The following is a description of a gene set: species: Mus musculus from publication Yevshin I, Sharipov R, Kolmykov S, Kondrakhin Y, Kolpakov F (PMID 30445619) Mouse Gene Set: ZFP808_TARGET_GENES, and this is the list of marker genes: Gm15901, Hspa8, Tyw1, Lag3, Gm6872, Ogt, Ube2i, Slc43a1, Gm19815, Gm4847, Sema4d, Atg16l1, Dnajb2, Abo, Fhip2b, Stk38l, Ptrh2, Alg11, Hspa4, Gm24400, Ppp2r5c, Rps27a-ps3, Irf8, Hsd11b1, Bloodlinc, Arrdc3, Spcs1, Lst1, Mrm2, Gm2800 (predicted gene 2800), Lyg1, Dclre1a, Limk2, Setd7, Agpat2, Pdia3, 2210417A02Rik, Dnai2, Cxxc1, C030013C21Rik, Slc1a2, Lrp2 (low density lipoprotein receptor-related protein 2), Gm8398, Fau-ps2, Znfx1, Hhip, Jakmip1, Ninj2, Hsp90ab1, Mrpl30, Ints5, Gm15032, Msrb3, Slc1a3, Fastkd5, Nabp2, Lztr1, Foxp1, Fam83c (NCBI Gene Id 71405), Kcnt2, Mpi, Pou2f2, Gtdc1, Sinhcaf, Galnt17, Adamts19, Atp5f1a, Hyls1 (HYLS1, centriolar and ciliogenesis associated), Tram1, Sass6, Dhtkd1, Ino80d, Bola2, Maf, Prkag1, Tor1aip1, Ash2l, Fcgr3, Phf24, Cbfb, B4galt6 (NCBI Gene Id 56386), Babam1, Xpr1, Gm26207 (predicted gene, 26207), Gm7027, Pisd-ps1, 4933406P04Rik, Naprt, Ddx19a, St13, Gripap1, Plcd4, Gm12980, P2rx7, Sez6, Snhg14, Nell1, Top3a, Hspa9, 2610206C17Rik, Vcp, Gm5764, Tra2a, Bcl2l1, Ercc2, Il4, Cd180, 2810407A14Rik, Slc6a4, Slc22a19, Mirlet7f-2, Zfat, B4galt7, Dgcr8, Pdcd6ip, Ech1, Diaph1, Gm12440, Bcas1, Gm10069, Tspyl2, Poc1a, Prss40, Rsrp1, Spmip3, Fkbp4, Pomgnt1, Timm13, 4933434E20Rik, Cep41, Wfs1, H2-M5, Atrnl1, Ino80dos, Prss54, Phox2b, Zfp7, Phlpp2, 0610031O16Rik, Tldc2 (TBC/LysM associated domain containing 2), Eef1a1, Eaf2, Cldn22, Gm23054, Matk, Mbtps2, Gm12936, Psmd2, Niban2, Nipbl, Prrt1b, Ywhag, 4932412D23Rik, Tfdp1, Mir124a-1hg, 9430015G10Rik, Gm15927, Crem, Gm26885, Gm12125, Myh13, Cp, Eva1c, Rabl6, Vwa3b, Med1, Mir1306, Mgst2, Tdrd9, Vmn1r193, Nr6a1os, Gm12892, Usp14, Eri3, 1700023H06Rik, Fbxo21, Snora57, Gm12740, Rpl35a-ps6, Psma3, Mir7057, Mir98, Snx1, Utp25, Gm7094, Ubqln4, Zfp207, Best4-ps, Gm14095, Tsc22d4, Rpl38, Ctsh, Glis3, Dgkz, Gm29707, Rtl1, Nuak2, Pou6f1, Zbtb8a, Gm22973, Gm28874, Arhgap4, Mkks, Gm10532, Iho1, Treml4 (triggering receptor expressed on myeloid cells-like 4), Ptp4a1, Zpbp2, Gm24461, Mcm2, Morc4, Rhot1, Gm24888, Clec2l, Myo18a, Itpr2, Doc2g, Fbrsl1, Gm13207, Sp1, Gm22935, Clec2d, Unc13b, Dpep3, Tigd4, Fam193b, Sos1, Cldn34c1, Lrrc23, Meg3, Mir7664, Psph, Anp32e, Ly6g, Atcay, Spns1, Gemin2 (gem nuclear organelle associated protein 2), Rbm41, Zfp36l1, Gm11149, Ttf2, Mdk, Gnl3, Tulp3, Plcb2, Gm25369, Tgif1, Vwf, Xpnpep3, Fam98c, Mir99ahg, Frrs1, Bmt2, Gm12091, Dhx9, Hsph1, Misp, Abca16, Slc25a2, Xpnpep2, Slx1b (SLX1 structure-specific endonuclease subunit homolog B (S. cerevisiae)), Gamt, Zfp809, Mzf1 (NCBI Gene Id 53862), Tatdn2, Spry4, Gm9887, Ckap2, H3c11, Foxc1, 1700120B22Rik, Abcc3, Sbno1, Rsf1, Dync1h1, Gm3830, AY074887, Gm13842, Mgst3, Slc2a3, Zfp143, Arhgap26, Slx4ip, Nmnat3, Evl, C630004M23Rik, P2rx3, Ppp4r4, Dsc1, Trpm1, Pla2g6, Arhgap27os1, Tpm3, Stap2, Klhl18, Trim36, Zfp865, Gm27219, Bin2, Cdc42ep1, Tcf4, Adarb1, Fam193a, Zfp747l1, Chchd2-ps, Aste1, Lgmn, Rnf6, Vac14, Mir7668, Fuca1, Dnaaf9 (NCBI Gene Id 98941), Atp7a, Gm9496, Znrf4, Gm23382 (predicted gene, 23382), Trp53cor1, Hoxa7, 5031434O11Rik, Ipo13, Fam216a, Cep85, Ly96, Vgll4, 1700001K19Rik, Mpnd, Tor1aip2, Rora, Kdm5a, Syt3, Traj58, Tpk1, Rad54l, Gm14210, Gnl3l, Tango2, Ccndbp1, Igfbp4, 4931406C07Rik, Recql5, Itih3, Hexd, Tshz1, Gtf2i, Uba1, Nme4, Npdc1, Nrde2, Stk32b, Zfp82, Capza1, Inpp5b, Cyb5r1, 4930447F24Rik, Kif20a, Hmgb1, Amz1, Taf1d, Agap1, Plekha6, Ptges3, Atrip, Slc7a3, Agtrap, Myo15a, Suv39h1, Oplah, Mir7035, Phf20, Gm43772, Tanc1, Nadk2, Capn10, Mir5136, 1700020L13Rik, Gm16096, Mtif3 (mitochondrial translational initiation factor 3), Babam2, Strada, Wdfy3, Rnf170, Ankrd40, Bmal1, Esr1, Agap3, Gm26211, Atp6v0a1, Gtf2a1, Defb47, Hint1, Tamm41, 1110028F18Rik, Pask, Catsper2, Ubxn1, Gm11665, Zc3hc1 (NCBI Gene Id 68773), Scin (scinderin), Oas2, Rwdd4a, Fignl1, Surf6, 4933440N22Rik, Setd1a (SET domain containing 1A), Adat1, Gsdma2, Chrna9, Pls3 (NCBI Gene Id 236867), Tle2, Arl2bp, Mfsd14b, Gak, Elk4, Sptan1, Klf1, Ammecr1, 2410002F23Rik, 4930512H18Rik, Pglyrp3, Lars1, Arpp21, Mrpl14, 2010109A12Rik, Mir3618, Zfr (zinc finger RNA binding protein), Zfp27, Gm4535, Faddos, 2310011J03Rik, Adig, Tmco2, Gm28836, Gm14111, Shmt1, Gm12654, Gm13010, Kat2b, Gm9955, Or10ad1, Gm42799, Trip12, Rexo2, Rprl3, Mir8090, Nrbp1, Tsg101, Metap2, Pdgfd, 4930509H03Rik (NCBI Gene Id 75107), Rps6kb1, Gpn3, Rhbdd2, Cdh13, Klhl22, Ascl4, Map3k8, Slc22a7 (solute carrier family 22 (organic anion transporter), member 7), Luc7l3, Acad11, Xpnpep1, A230083N12Rik, Trim67, Cnbd2, Gm15610, Appl1, Amigo1, Ifrd1, Nbeal2, Pde4d, Gm8186, Zmat1, Rplp2, Mettl13, Nudt1, Tfrc, Tmem242, Glrx5, 4930451E10Rik, Zfp101, Irf3 (NCBI Gene Id 54131), Gm12803, Uba52, Mroh1, Slc12a6, Rapgef6, Ptbp1, Aars1, Sirt7, Arpc5l, Zfp395, Mrpl28, Racgap1 (NCBI Gene Id 26934), Top3b, Adar, Slc2a9, Thrap3, Golga7, Zfp975, 1500015A07Rik, 2900079G21Rik, Pdpr, Smg7, Rnf125, Hsp90aa1, Gm19705, Lcn12, Gm11191, Ddb2, Gm973, Ywhaq (NCBI Gene Id 97839), Cyp4a28-ps, Dtymk, Mir7075, Ushbp1, Trap1 (TNF receptor-associated protein 1), Sumf2, Terf2, Tfap4, Nphp1, Carhsp1, Neu1, Dlgap5, Nhlrc2, Ift140, Ltbp1, Tomm34, Ercc6, Pcdhb22